The following is a description of a gene set: Mouse Gene Set: GOBP_AMINO_ACID_BETAINE_METABOLIC_PROCESS The chemical reactions and pathways involving any betaine, the N-trimethyl derivative of an amino acid. studied in species Mus musculus, and this is the list of marker genes: Bbox1, Cpt1a, Cpt2, Aldh7a1, Acadm, Cpt1c, Slc22a4, Acadl, Aldh9a1, Slc22a5, Cpt1b, Crot, Bhmt1b, Dmgdh, Chdh, Bhmt, Crat